The following is a description of a gene set: Any process that stops, prevents or reduces the frequency, rate or extent of cell chemotaxis to fibroblast growth factor. Human Gene Set: GOBP_NEGATIVE_REGULATION_OF_CELL_CHEMOTAXIS_TO_FIBROBLAST_GROWTH_FACTOR studied in species Homo sapiens, and this is the list of marker genes: MIR15A, MIR149, MIR16-1, MIR424, CXCL13